The following is a description of a gene set: Hyperexcitability of the neuromuscular system related to abnormally low level of calcium in the blood, resulting in carpopedal or generalized spasms. Hypocalcemic tetany studied in species Homo sapiens Human Gene Set: HP_HYPOCALCEMIC_TETANY, and this is the list of marker genes: GNAS, ENPP1, FOXN1, DMP1, FAM111A, AIRE, STX16, CTNS, TBCE (tubulin folding cofactor E)